Given this list of marker genes H4c6, Nr4a3, Pip4p1, Zfp947, Tcea1, Ldb1, Nr3c1, Cul1, Gtf2f2, Psma3, Phf20, H2bc7, Cbfb, Lamtor1, Sirt1, Cited2, Pcgf6, Cox4i2, Cradd, Ccng1, H3c8, Psma4, Pdpk1, Lamtor5, H2bc9, Zfp493, Zfp69, Triap1, Tbl1x, Pcna, Zfp324, Serpinb13, Zfp446, Zfp808, Tal1, H2ac24, Cox6a1, Daxx, Zfp612, Ing2, H2bc15, Yap1, Zfp867, H3c6, Tcf3, Zfp39, Ercc2, Gm45871, Rarg, Taf1, Cbx6, Cbx4 (NCBI Gene Id 12418), Ash2l, Cnot4, Zfp930, Zfp946, Zfp758, Zfp456, Dyrk2, Bmi1, H2az2, Tcf7l1, Rpa1 (replication protein A1), Zfp788, Yaf2, Sesn2, Zfp729a, H3c3, Psmd1, Nr2e1, Ring1, Plk2, Nrbf2, Ddit4, Nr4a2, Zfp385a, Pparg, Cox8c, Rheb, Zfp74, Pip4k2c, Gtf2h2, Rbbp7, Rxrb, H2ac15, H4c14, Npas4, Rorb, H2ax, Zfp938, Ywhae, Gm14391, Ccnh, Psma5, Taf15, Prdx5, Zfp991, H2bc12, Polr2e, Pou4f2, Lmo2, Esr2, Psmd12, Brca1, Zfp418, Ube2d1, Wrn, Gm10033, Smarcd1, Zfp119b, Ppp1r13l (protein phosphatase 1, regulatory subunit 13 like), Txnrd1, Tfap2e, Zfp141, H4c4, Zfp65, Ubb, Zfp35, Nr1d2, H4c2, Polr2f, H2ac10, Psmc2, Ppm1d, Nr1h4, Thrb, Zfp747l1 (NCBI Gene Id 78921), H4c1, Zfp691, Bard1, Med1, Cdk1, Zfp959, H2ac7, Zfp799, Elf1, Mapk11, G6pdx (glucose-6-phosphate dehydrogenase X-linked), Tcf7, Psmb6, Supt5, Gm4924, Cbx2, E2f7, Kat5, Zfp1, H4c11, Tead2, Hnf4g, Zfp354b, Zscan25, Ccna1, Steap3, Wwtr1, Map2k6, Maged1, H3c13, Sumo1, Ctdp1, Smurf1, Bax (BCL2-associated X protein), Zfp268, Cited4 (Cbp/p300-interacting transactivator, with Glu/Asp-rich carboxy-terminal domain, 4), Gls2, Smad3, Myc, Zfp825, Tfdp1, Rorc (RAR-related orphan receptor gamma), H4c3, Psma1, H2bc27, Taf10, Taf4b, Cox6a2, Polr2k (polymerase (RNA) II (DNA directed) polypeptide K), Zim1 (zinc finger, imprinted 1), Nr5a1, Zfp763, Zfp175, Zfp971, Ccne1, Rbbp8, Psmc1, Sfn, Hdac8, Zfp775, Gtf2f1, Kmt2b, Trp63, Zkscan7, Txn1, Nr2f6, Ccne2, Hus1, Zik1 (zinc finger protein interacting with K protein 1), Zfp987, Nelfa, Zfp94 (zinc finger protein 94), H3c2, H4c17, Rragc, Cox6c, Zfp454, Zfp27, Lamtor4, Aurkb, Gata2, Zfp383, Ywhah, Zfp955a, Zfp677, Cox7a2l, Supt16, Zkscan5, Ehmt1, Zkscan17, H4c9, Zfp386, Psmc3, Zfp934, Smarcc1, Zfp566, H2ac22, Prdm9, Cdc25c, Arnt2, H4c8 (NCBI Gene Id 69386), Ep300 (NCBI Gene Id 328572), Zfp688, Igfbp3, Zkscan4, Zfp989, Rad1, Gtf2h4, Zfp750, Chek2, Zfp995, Smad1, Rfc3, Zfp943, Zfp942, Zfp992 (zinc finger protein 992), Cnot10, Csnk2b, Psmc5, Zfp617, Ncor2, H2bc3 (H2B clustered histone 3), Taf9b, Smad7, Zfp457, Zfp772, Tbp, Rara, Pcgf2, Polr2i, Krba1, Brpf1 (bromodomain and PHD finger containing, 1), Cox4i1, Mre11a, Zfp212, Zfp583, Cdk13, Prkag3, Ppp2r1b, Cnot7, H3c1, Dna2, Tgfb1, Zfp791, H2ac20, Nr2f1, Zfp595, Supt4a, Zfp445, Cga, Zfp931, Men1, Sgk1, Zfp747, Smarca4, Cdkn1b (NCBI Gene Id 12576), Zfp647, Zfp455, Zfp551, Max, Taf8, Zfp804b, Nelfe, H2bc8, Zfp746, H2bc1, Zfp786, H2ac13 (H2A clustered histone 13), Ccnb1, Mapk14, Cdk12, Smarcc2, Polr2c, Zfp605, Hdac11, Polr2b, Gata1, Setd1a, Blm, Tead4, Cdk4, Zfp764, Zfp715, Zfp429, Zkscan3, Tpx2, Nr2c2, Nuak1, Zfp14, Gpx2, Psma2, Gata3, Psmb4, Zfp655, Ercc3, Psmb5 (NCBI Gene Id 19173), Zfp689, H3c10, H3f3a, Mta2, Tfap2d, Prelid1, Rabggtb, Mapk3, Brpf3, Psmc4, Zfp982, H2bc22, Zfp994, H3c7 (H3 clustered histone 7), Esrrb, Smarcd2, Cycs, Actl6b (actin-like 6B), Zfp708, AU041133, H2ac11, H2ac19, H4c18, Psmd6, Zfp273, Ezh2, Zfp735, Polr2l, Lbr, Rxrg, H2ac8, Zfp46, Zfp169, Top3a, Gadd45a, Cdk5, Rraga, Smarcb1 (SWI/SNF related, matrix associated, actin dependent regulator of chromatin, subfamily b, member 1), Psma7, Rps27a, Nbn, Arid1a, Gm5141, Taf7, Trp53, Foxo4, Rad9a, Taf11, Mapkapk5, Zfp641, B020011L13Rik, Phc1, Casp2, Cdk8 (cyclin dependent kinase 8), H3c11, Prmt5, Atp1b4, Esrrg, H2bc11, Tcf7l2, Zfp600, Tgif1, E2f6, Zfp811, Zfp964, Psmd13, Cenpj, H2ac4, Zfp61, Zfpm1, Sin3a, Lamtor2, Scmh1, Hdac10, H4c12, Snw1, Zfp955b, Zfp759, Zfp839, Taf12, Zfp740, Banp, H2bc13, Ndufa4, Hdac4, Tbx5, H2ac12, Notch3, Zfp582, Zfp784, Prkag1, Zfp770, Esr1, Zfp940, Zfp58, Zfp37, Cdkn1a, Ar, L3mbtl2, Vdr, Npm1, Zfp738, Zfp990, Zfp872, Bmal1, Taf13, Nr4a1 (NCBI Gene Id 15370), Prdx1, Rnf111, Zfp606, Cited1 (NCBI Gene Id 12705), Gm7072, Cbx8, Psma6, Runx2, Zkscan8, Rarb, Trp73, Cox7c, Nr0b1, Zfp101, Taf5, Tsc1, Zfp712, Psmc6, Tfap2a, Zfp286, Cox7a1, Ctnnb1, Nek4, Pax5, Smurf2, Zfp661, Zfp317, H3c15, Rbbp4, Psmb7, Zfp420, Zfp458, Zfp90, Hdac7, Hdac3, Psmd7, Ppp1r13b, Zfp473, Rabggta (NCBI Gene Id 56187), Zfp12, Zfp112, Taf6, Ccnd1, Zfp703, Zfp202, Cox8a, Zfp354a, H2ac1, Foxo6 (NCBI Gene Id 329934), H2ac23, H2ac6, Tnks1bp1, H3c4, AI987944, Zfp113, Gm14325, Zfp667, Zfp619, Nr0b2, Higd1c, Polr2a, Nr1i2, Mbd3, Foxp3, Taf7l, Rsl1, Hnf4a, Cox5a, Zfp263, Rictor, Smarca2, Atad2, here is a description of the gene set: studied in species Mus musculus part of: RNA Polymerase II Transcription electronically inferred by orthology from the curated human pathway Reactome Pathway: Generic Transcription Pathway This event has been computationally inferred from an event that has been demonstrated in another species.<p>The inference is based on the homology mapping from PANTHER. Briefly, reactions for which all involved PhysicalEntities (in input, output and catalyst) have a mapped orthologue/paralogue (for complexes at least 75% of components must have a mapping) are inferred to the other species.